Given this list of marker genes Pdgfb, Fgf9, Sod2, Dnmt1, Olfm2, here is a description of the gene set: Mouse Gene Set: GOBP_REVERSIBLE_DIFFERENTIATION studied in species Mus musculus A phenotypic switching process where a cell reversibly differentiates and dedifferentiates from one cell type into another.